The following is a description of a gene set: PURPOSE: To elucidate the molecular mechanisms contributing to the unique clinicopathologic characteristics of mucinous ovarian carcinoma, global gene expression profiling of mucinous ovarian tumors was carried out. EXPERIMENTAL DESIGN: Gene expression profiling was completed for 25 microdissected mucinous tumors using Affymetrix U133 Plus 2.0 oligonucleotide microarrays. Hierarchical clustering and binary tree prediction analysis were used to determine the relationships among mucinous specimens and a series of previously profiled microdissected serous tumors and normal ovarian surface epithelium. PathwayAssist software was used to identify putative signaling pathways involved in the development of mucinous LMP tumors and adenocarcinomas. RESULTS: Comparison of the gene profiles between mucinous tumors and normal ovarian epithelial cells identified 1,599, 2,916, and 1,765 differentially expressed in genes in the cystadenomas, LMP tumors, and adenocarcinomas, respectively. Hierarchical clustering showed that mucinous and serous LMP tumors are distinct. In addition, there was a close association of mucinous LMP tumors and adenocarcinomas with serous adenocarcinomas. Binary tree prediction revealed increased heterogeneity among mucinous tumors compared with their serous counterparts. Furthermore, the cystadenomas coexpressed a subset of genes that were differentially regulated in LMP and adenocarcinoma specimens compared with normal ovarian surface epithelium. PathwayAssist highlighted pathways with expression of genes involved in drug resistance in both LMP and adenocarcinoma samples. In addition, genes involved in cytoskeletal regulation were specifically up-regulated in the mucinous adenocarcinomas. CONCLUSIONS: These data provide a useful basis for understanding the molecular events leading to the development and progression of mucinous ovarian cancer. Genes down-regulated in mucinous ovarian carcinoma tumors of grades 1 and 2 compared to the normal ovarian survace epithelium tissue. from publication Wamunyokoli FW, Bonome T, Lee JY, Feltmate CM, Welch WR, Radonovich M, Pise-Masison C, Brady J, Hao K, Berkowitz RS, Mok S, Birrer MJ (PMID 16467078) species: Homo sapiens Human Gene Set: WAMUNYOKOLI_OVARIAN_CANCER_GRADES_1_2_DN, and this is the list of marker genes: ST13, HBB, FAM153A, PODXL, KDR, CLIP4, SSBP3, SRSF5, RHOQ, SPRY1, IFT52, ANXA8, N4BP2L2, C4A, FRMD4B, CPE, PPM1K, ID4, RGL1, SERPING1, TTC28, SFPQ, TCEAL3, TCEAL2, HOXD8, PLSCR3 (phospholipid scramblase 3), RARRES1, ZNF641, DDX17, WT1, C3, PARP6, SLC26A11, DPYD, DOCK4, IGFBP6, TMX4, HERC2P9, MNDA, ATP2B4, WSB1, CLIC5, SULF1, MAGI2-AS3, NISCH, SBSPON, PDGFD (NCBI Gene Id 80310), GAS1, PTGS1, SNCA, CFI (complement factor I), FLRT2, RUFY3, DOCK11, BNIP3, BASP1, ELOVL5, CAV1, LGALS8, IFITM2, CELF2, DAB2, PLSCR4, ZNF483, EEF1A1, CTDSP2, SH3BP5, PROCR, IL1R1, TIAM1, ARMCX1